Given this list of marker genes SMARCA5, PAK4, CCDC74B, PCGF2, FNTA, TBCB, KCNQ4, RAB9A, ZFYVE16, CTTNBP2NL, TAPT1-AS1, FEV, TRPC4AP, ACVR2A, RTF1, CCDC74A, PMM1, DCUN1D4, UTP18, NRG2, PTPN2, CAMK2G, GGA1, HIPK1, DMTF1, MIR22HG, TAPT1, NXPH4, SH3KBP1, EFCAB13, JADE2, ARHGEF1, PHF21A, PTOV1, ARRDC1-AS1, SLC46A1, TIPRL, ZNF524, HES7, NFAT5, ERC1, GRB2, CACNA1D, DDB1, RCOR2, PRMT1, RBM4B (RNA binding motif protein 4B), FKBP8, CREB1, APLP2, FLII (NCBI Gene Id 2314), RHOG (ras homolog family member G), MAP3K11, FIS1, KANK2, OSBPL9, RAB2B, POU5F1, FAM217B, CADM2, AGBL5, VAMP2, PEX14, HSPB2, TLCD4, ZFP91, FKBP14, PIAS1, GAS7, FBXL19-AS1, CPD, ACER3, CLSTN1, SMARCE1, MYLIP, RBBP7, CDC25A, THRA, ERBB3, TAF11, CDC40, SLBP, CDKL5, ATP2A2, CHD6, PRSS12, KLF13, CYP26B1, NDRG1, KCNN2, SH3BP5, RELA, TIMP3 (TIMP metallopeptidase inhibitor 3), PUSL1, CORO1C, MRPL49, EFEMP2, CRY1, KAT2A, PTBP3, HOXB7, MXD4, NFYC, BAD, PRICKLE3, KDM2A, TMEM256, PER1, POU3F2, RPL7, ACE, MAP3K7, PTK7, OAZ2, PRKRA, ZBTB5, ERO1B, CRYAB, SLC9A6, IQGAP1, CHKA, PIGV, PPP1R36, TCF4, WDR81, SH2D3C (SH2 domain containing 3C), SIPA1, EPS15, SMIM19, ME3, TRIM28 (tripartite motif containing 28), SNX18, WASF1 (WASP family member 1), CACNA1A, KCNB1, TIMELESS, LDB1, ARHGAP36, GGN, STMN1, CDCA7, UPF2, UGP2, EML3, VKORC1L1, LHX3, GRIN2A (glutamate ionotropic receptor NMDA type subunit 2A), SLC18A3, GK, DDAH2, ASIC1, RBM15B, SPAST, PLPPR2 (NCBI Gene Id 64748), PLEKHA8, CTR9, ABHD1, CDC37, PITPNA, HSPB9, KLF2, SOX2, NUB1, CHAT (NCBI Gene Id 1103), CSNK1D, MAP4K2, KANSL1L, NLK, HTR7, GOLGA3, ANKS1A, NEFM, SPAG9, CBLN1, IRX3, C11orf68, S1PR5, HCN4, SNX2, NXPH3, ONECUT1, TEAD2, RHBDL3, KLF11, DRAP1, PIAS3, NCOA6, TMEM150A, PSMC6, C2CD2L, ELL, IGF2BP1, CACNA1B, MIEF2, STARD13, PCIF1, KIF16B, AKT2, POLR2I, PHOX2A, ACSF2, DYNLL1, FGF12, MAP2K7, CNNM4, CDK5R1, ING2, ZNF282, INO80, PHF23, ANP32A, GLI1, CGGBP1, LYRM1, TAF6, ROM1, GLTP, ASCL2, SNAPIN, ZNF414, UBE2O, SYT9, RAP1GDS1, ZNF48, HAP1, HYAL2, BCL2L2, TLX2, NPAS4, NTF4, FHIP1B, XRCC6, DCAF1, BMPR2, SOX12, SLC35F5, FBXO36, PDIK1L, TKFC, PPARGC1B, WNT2B, WHRN, PPP1R3D, COPS5, CADM1, LOXL4, ELK1, SPATA6, CNPY4, SMARCD1, GPRASP1, LRRC8E, BCL11B, EMSY, TRIM27, BCL6B, GNA11, RNF24, GPR3, WNT2, here is a description of the gene set: studied in species Homo sapiens Genes having at least one occurrence of the motif NGGGGGCGGGGYN in the regions spanning 4 kb centered on their transcription starting sites. This matches the SP1 transcription factor binding site V$SP1_Q6 (v7.4 TRANSFAC). Human Gene Set: SP1_Q6